Given this list of marker genes PSD3, RAG1, LINC00426, PECAM1, ITGA5, CD27, CKMT2, SH2D4B, H1-0, C1QTNF4, TNFRSF1A, SOCS2, LILRA2, CD34, LINC01013, ELK3, EGFL7, ENG, DNTT, GSN, TRGV9, GNG11, ERG, SMIM3, SORBS3, FHIT, GBP4, SCHIP1, SLC8A1-AS1, ADA, here is a description of the gene set: studied in species Homo sapiens from publication He P, Lim K, Sun D, Pett JP, Jeng Q, Polanski K, Dong Z, Bolt L, Richardson L, Mamanova L, Dabrowska M, Wilbrey-Clark A, Madissoon E, Tuong ZK, Dann E, Suo C, Goh I, Yoshida M, Nikolić MZ, Janes SM, He X, Barker RA, Teichmann SA, Marioni JC, Meyer KB, Rawlins EL (PMID 36493756) Late pro-B Human Gene Set: HE_LIM_SUN_FETAL_LUNG_C5_LATE_PRO_B_CELL